The following is a description of a gene set: Any process that stops, prevents, or reduces the frequency, rate, or extent of antigen processing and presentation. Mouse Gene Set: GOBP_NEGATIVE_REGULATION_OF_ANTIGEN_PROCESSING_AND_PRESENTATION species: Mus musculus, and this is the list of marker genes: Hfe, H2-Oa, Cd68, Tapbpl, Thbs1, H2-Ob (NCBI Gene Id 15002), Fgl2